Given this list of marker genes Gdf7, Nr5a2, Mkx, Bmp4, Scx, here is a description of the gene set: species: Mus musculus Mouse Gene Set: GOBP_TENDON_FORMATION The process that gives rise to a tendon. This process pertains to the initial formation of a tendon from unspecified parts.